Given this list of marker genes EXOSC4, XRN1, MAPKAPK2, EXOSC7 (exosome component 7), EXOSC1, YWHAB, EXOSC2, ZFP36, EXOSC6, EXOSC5, DCP1A, EXOSC3, EXOSC8, DCP2, DIS3, EXOSC9, TNPO1, here is a description of the gene set: Tristetraproline (TTP) binds RNAs that contain AU-rich elements and recruits enzymes that degrade RNA. TTP interacts with the exosome (3' to 5' exonuclease), XRN1 (5' to 3' exonuclease), and the decapping enzymes DCP1 and DCP2a.<br>The activity of TTP is regulated by phosphorylation. MK2 phosphorylates TTP, which then binds 14-3-3.The interaction with 14-3-3 prevents phosphorylated TTP from entering stress granules and stabilizes mRNA bound by phosphorylated TTP. Tristetraproline is known to bind AU-rich elements in the following mRNAs: Tumor necrosis factor alpha (TNFA), Granulocyte-macrophage colony stimulating factor (CSF2, GM-CSF), Interleukin-2 (IL-2), and Proto-oncogene C-FOS (FOS, c-fos). Mice deficient in TTP exhibit arthritis, weight loss, skin lesions, autoimmunity, and myeloid hyperplasia. Reactome Pathway: Tristetraprolin (TTP, ZFP36) binds and destabilizes mRNA part of: Regulation of mRNA stability by proteins that bind AU-rich elements species: Homo sapiens